Given this list of marker genes NEIL3, APEX1, MPG, NTHL1, NEIL2, MBD4, UNG, TDG, PCNA, NEIL1, OGG1, SMUG1 (single-strand-selective monofunctional uracil-DNA glycosylase 1), RPS3, MUTYH, here is a description of the gene set: Catalysis of the removal of damaged bases by cleaving the N-C1' glycosidic bond between the target damaged DNA base and the deoxyribose sugar. The reaction releases a free base and leaves an apurinic/apyrimidinic (AP) site. Human Gene Set: GOMF_DNA_N_GLYCOSYLASE_ACTIVITY species: Homo sapiens